Given this list of marker genes TFAM, TFB2M, POLRMT, here is a description of the gene set: Human mtDNA is transcribed by a dedicated mitochondrial RNA polymerase (POLRMT), which displays significant sequence similarity to the monomeric RNA polymerases found in bacteriophages. In contrast to the phage T7 RNA polymerase, POLRMT cannot interact with promoter DNA and initiate transcription on its own, but requires the presence of the mitochondrial transcription factor A (TFAM), and either transcription factor B1 (TFB1M) or B2 (TFB2M). The 4 proteins of the basal mitochondrial transcription machinery have been purified in recombinant form and used to reconstitute transcription in vitro with a promoter containing DNA fragment. Although both TFB1M and TFB2M can support in vitro transcription with POLRMT, TFB2M is at least two orders of magnitude more active than TFB1M and the physiological role of TFB1M in mitochondrial transcription has not yet been completely defined. The TFB1M and TFB2M display primary sequence similarity to a family of rRNA methyltransferases, which dimethylates two adjacent adenosine bases near the 3' end of the small subunit rRNA during ribosome biogenesis. Human TFB1M is, in fact, a dual function protein, which not only support mitochondrial transcription in vitro, but also acts as a rRNA methyltransferase. The methyltransferase activity is not required for transcription, since point mutations in conserved methyltransferase motifs of TFB1M revealed that it stimulates transcription in vitro independently of S-adenosylmethionine binding and rRNA methyltransferase activity. studied in species Homo sapiens part of: Transcription from mitochondrial promoters Reactome Pathway: Mitochondrial transcription initiation